Given this list of marker genes ADAM15 (ADAM metallopeptidase domain 15), ZFAND2B, PPP1R16B, KCTD20, TAF1, PPP1R14B, KAT5, CTR9, WDR37, FBXW5, ZSCAN18, SLC66A2, METTL3, ATG4B, ACTR1B, ELK3, DPH7, DTX4, SIN3B, SPSB3, ITPKB, SREK1, GLT8D1, PYCR2, LETM1, RXRB, ATP6V0A2, GRPEL2, PLEKHM2, LZTR1, ZNF451, FZD4, RALGDS, PCID2, MFNG, RAPGEF3, PRELID1, SEMA3F (NCBI Gene Id 7868), GMPPA (GDP-mannose pyrophosphorylase A), GATA2, MTURN, RNF31, STC1, OSBPL5, HARS2, EDC4, SLC25A44, WDR74, ARAP3 (NCBI Gene Id 64411), XAB2, GAS6, TCERG1, ATRX, ITPR1 (NCBI Gene Id 619543), ADCY6, BCOR, HDHD5, MCM7, MICAL3, MEIS1, ZBTB44 (NCBI Gene Id 29068), KLHDC3, ASB1, THOC6, INTS11, ZSWIM8, ADAMTS2, AKAP17A, DLL1, INPP5A, MAF1, MBIP, FAM118A, SGSM3, MAFG, NCAPH2, CRIP1, BAP1, SGSM2, PIK3IP1, TCF25, VPS54, SMTN, PPP6R2, TUBA4A, SNX11, ENTPD6, MADD, TSR1, PLXNA2, HMCES (NCBI Gene Id 56941), LRRC47, MPHOSPH10 (NCBI Gene Id 10199), ARRDC2, TRAK1, ULK3, GAK, THAP2, EIF4E2, CFAP20, ARHGAP10, TFIP11, NOTCH2NLA, NFATC2, CC2D1B, DCHS1, GUCD1, MYO1D, PRKY, MRTFA, RSAD1, FOS, SMPD4, EXOSC7, SLC9A1, PODXL, C2CD2, LCN10, BAALC, FAM32A, RASA3, BCR (NCBI Gene Id 729775), STARD10, NDST1, MOAP1, ZC3H7A, H2AJ, NES (nestin), CFAP36, ARHGEF15, PLEKHM1, LMBR1L, LDB1, TTC7A, SLC25A29, RRAD, SFN, PPP1R13B (protein phosphatase 1 regulatory subunit 13B), C19orf48P, DOCK6 (dedicator of cytokinesis 6), CHFR, SLC25A4, ZNF160, CRY2, ENTR1, SPRED1, SEPHS1, NR1D2, PRKAB1, RASSF1, TXNDC11, MFAP1, CYP1A1, ILVBL, EDC3, CD82, CTCF, BLCAP, NEBL, PER1, RNMT, SKIC2, F2RL3, SH3PXD2B, FHIP2B, XPC, PHLDB1, YJU2B, TMEM255B, MLXIP, TBCD, MDC1, SPHK1, S100A13, ITPA, here is a description of the gene set: Genes strongly down-regulated (og2(FC)<-3.58, padj<0.05) in post mortem lung tissue from COVID-19 patients vs uninfected biopsy. from publication Blanco-Melo D, Nilsson-Payant BE, Liu WC, Uhl S, Hoagland D, Møller R, Jordan TX, Oishi K, Panis M, Sachs D, Wang TT, Schwartz RE, Lim JK, Albrecht RA, tenOever BR (PMID 32416070) Human Gene Set: BLANCO_MELO_COVID19_SARS_COV_2_POS_PATIENT_LUNG_TISSUE_DN studied in species Homo sapiens Transcriptional profiling of post-mortem lung samples from COVID-19-positive patients (N=2) compared with biopsied healthy lung tissue from uninfected individuals.